Given this list of marker genes Slit3, Rnf113a1, Padi2, Ccl5, Sh2b3, Rnf113a2, Robo1, Slit2 (slit guidance ligand 2), here is a description of the gene set: Any process that decreases the rate, frequency or extent of a chemokine-mediated signaling pathway. Mouse Gene Set: GOBP_NEGATIVE_REGULATION_OF_CHEMOKINE_MEDIATED_SIGNALING_PATHWAY studied in species Mus musculus